The following is a description of a gene set: studied in species Mus musculus The process in which vesicles are directed to specific destination membranes during transport from the rough endoplasmic reticulum to the cis-Golgi. Mouse Gene Set: GOBP_VESICLE_TARGETING_ROUGH_ER_TO_CIS_GOLGI, and this is the list of marker genes: Preb, Trappc12, Sec16a, Klhl12, Pdcd6, Pef1, Trappc4, Trappc1 (NCBI Gene Id 52555), Trappc11, Trappc6a, Sar1b, Trappc2, Trappc3, Trappc5, Sar1a, Mapk15, Trappc2l, Cul3